The following is a description of a gene set: Mouse Gene Set: GOBP_NOTOCHORD_MORPHOGENESIS The process in which the anatomical structures of the notochord are generated and organized. The notochord is a mesoderm-derived structure located ventral of the developing nerve cord. In vertebrates, the notochord serves as a core around which other mesodermal cells form the vertebrae. In the most primitive chordates, which lack vertebrae, the notochord persists as a substitute for a vertebral column. species: Mus musculus, and this is the list of marker genes: Gli1, Kdm6a, Wnt5a, Nog, Epha2, Nckap1, T, Wnt11, T2, Ppp1r35, Crb2, Efna1, Gli2